The following is a description of a gene set: Enables the transmembrane transfer of a solute by a channel that opens when a specific ligand has been bound by the channel complex or one of its constituent parts. studied in species Homo sapiens Human Gene Set: GOMF_LIGAND_GATED_CHANNEL_ACTIVITY, and this is the list of marker genes: BEST4 (bestrophin 4), CCT8L2, SLC1A7, CHRNB3 (NCBI Gene Id 1142), TMEM63A, TTYH1 (NCBI Gene Id 57348), HCN2, KCNJ5, ANO7 (NCBI Gene Id 50636), TRPA1, CHRNA4, GRIA4, PKD2L1, HTR3B, ITPR3, CNGB1, CHRNA5, CHRNA7, GABRB3, CLCA4, KCNJ12, SCNN1D, GABRG2 (NCBI Gene Id 2566), KCNK1, ASIC3, GABRB1, ITPR2 (inositol 1,4,5-trisphosphate receptor type 2), KCNJ16, MCOLN1, ASIC4, CNGA1, NMUR2, ANO6, GABRA4, TRPM8, KCNK2, GRIN3A, CALHM1, P2RX6, CLCA2, AQP1, GABRR1, KCNJ1, ABCC9, P2RX4, KCNMB4, GABRP, KCNJ9, TMEM63B, TPCN1, KCNJ14, CHRNA3, GLRB, KCNJ6, TRPC3, KCNJ13 (NCBI Gene Id 619535), GABRR2, KCNJ10, CHRNA9, HCN4, KCNN1, CHRNA2, GABRA3, GRIA2, RYR2, GRIK5, BEST1, CHRFAM7A, KCNJ8, KCNH2, KCNJ15, PKD2, SLC1A5, ANO3, ANO1, CNGA4, KCNMA1, KCNJ18, CAV1, CNGA3 (cyclic nucleotide gated channel subunit alpha 3), GABRG1, SHROOM2, CHRNB1 (cholinergic receptor nicotinic beta 1 subunit), CFTR, CATSPER1, ANO10, BEST2, ANXA6, GLRA3, KCNT2, GRIN2A, GRIN1, GABRR3, P2RX5, KCNN4, CHRNA6, P2RX2 (purinergic receptor P2X 2), HTR3A, HTR3E, HTR3D, ANO9, GRIN2D, CCDC51, SLC17A7, TRPM4, GABRA1, P2RX3, CATSPER2, KCNN3, KCNU1, GRIK2, HCN1, ANO2, KCNT1, TPCN2, ZACN, GRIK3, CHRNA10, P2RX7, KCNJ4, GRIK4, TRPM5, KCNMB2, CHRNB4, BEST3, GABRQ, RYR1, GRIN3B, ITPR1 (NCBI Gene Id 619543), GABRB2, KCNH3, ANO4, GRIA1, GRIK1, KCNJ3, CNGB3, PACC1, GRIN2C, KCNK18, KCNH6, CHRNA1, ASIC2, KCNMB3, KCNK6, GABRA2, GABRG3, TRPV1, GLRA2, GRIN2B, KCNJ2, ANO8, ABCC8, TTYH2, BNIP1, MCOLN2, GRID1, SCNN1G, PKD1L3, CHRNB2, GABRA6, ASIC5 (NCBI Gene Id 51802), TMEM63C, KCNMB1, MCOLN3, TTYH3 (NCBI Gene Id 80727), KCNJ11, KCNE2, SCNN1A, ANO5, SCNN1B (sodium channel epithelial 1 subunit beta), KCNN2, GABRD, CATSPER4, ASIC1, KCNH7, CNGA2, CHRND, GLRA1, CHRNG, GRID2 (NCBI Gene Id 2895), GABRA5 (NCBI Gene Id 727729), KCNA10, GABRE, TRPM2, CLCA1, GRIA3, AQP6, RYR3, CHRNE, P2RX1, HTR3C